The following is a description of a gene set: Hemiatrophy Undergrowth of the limbs that affects only one side. Human Gene Set: HP_HEMIATROPHY studied in species Homo sapiens, and this is the list of marker genes: EFNB1, HRAS, ZNF699, BPTF (NCBI Gene Id 348241), PSMD12, EBP